Given this list of marker genes CCR7, LCK, CARD11, CYLD, ADA, TRAT1, RAB29, NECTIN2, UBR2, PRKD2, TESPA1, RPS3, LIPA, CD226 (CD226 molecule), CD81, IKBKG, BCL10, KCNN4, RELA, here is a description of the gene set: Human Gene Set: GOBP_POSITIVE_REGULATION_OF_T_CELL_RECEPTOR_SIGNALING_PATHWAY species: Homo sapiens Any process that activates or increases the frequency, rate or extent of signaling pathways initiated by the cross-linking of an antigen receptor on a T cell.